The following is a description of a gene set: Neighborhood of DNMT1 DNA (cytosine-5-)-methyltransferase 1 in the MORF expression compendium studied in species Homo sapiens Neighborhood of DNMT1 Human Gene Set: MORF_DNMT1, and this is the list of marker genes: SSBP1, SREBF2 (NCBI Gene Id 6721), DNMT1, HNRNPR, YARS1, BAZ1B, BUB1B, NUDC, HDAC2, AFG3L2, HNRNPU, BUB3, EBNA1BP2, SF3A3, RAD54L, ATP5PO, HCFC1, SSRP1, CBFB, TREX2, ANP32A, CHAF1A, DNAJC9, ESPL1, SLBP, HDDC2, LMNB2, PPIE, NSD2, NASP (NCBI Gene Id 96573), MCM5, LBR, TRRAP, KXD1, GNB1, TRA2B, MAPRE1, SMC3, R3HDM1, XRCC5, IARS1, ZNF131, POM121, SNRPA, KHDRBS1, TCP1, RRM1, POLA2, CS (NCBI Gene Id 94822), PMEL, MCM3, TXNL4A, LSM2, KHSRP, PPM1G, GTF2A2, DUT, TARS1, DKC1, MCM6, HADH, NUP188, EIF3I, EIF1AX (eukaryotic translation initiation factor 1A X-linked), SPAG5, TARDBP, CCT5, NONO, TYMS, RUVBL2, PABPC4, TCEA1, RPIA, RAD23A, SRSF1, ATP5MC3, MCM2 (minichromosome maintenance complex component 2), MTREX, PRKDC (NCBI Gene Id 5591), GARS1, HNRNPM, DDX19B, TUBA3C, USP1, LRPPRC, H2AZ1, FUS, UPF3A, RFC4, XPO7, MRPS27, SAFB, PTGES3, SRRM1, NAE1, PRPF8, HNRNPD, PDIA6, GOT2, DNAJC11, SNRNP200, TCERG1, ESD, NUDT1, STMN1, TNPO3, FH, VDAC3, CLPP, CDK11A, ZWINT, IMMT, HNRNPA2B1, XPO1, SRPK1, TFDP1 (transcription factor Dp-1), VDAC2, PPP1CC